The following is a description of a gene set: species: Mus musculus Mouse Gene Set: GOMF_KINASE_ACTIVITY Catalysis of the transfer of a phosphate group, usually from ATP, to a substrate molecule., and this is the list of marker genes: Nek6, Ccno, Nek3, Npr1, Fam20c, Plk4, Nrg1, Pdgfra, Fgfr2, Trp53rkb, Spred2, Gm7168, Igtp, Fgfr3, Map3k8, Grm5, Fermt2, Mast3, Gucy2f, Tkfc, Nme7, Hspa5, Phkg2, Pik3c2b, Irs3, Camkv, Cdk19, Hk2, Egf, Tyro3, Adk, Mark4, Etnk1, Fer, Ins1, Pmp22, Agap2, Ros1, Lrrk2, Ccl3, Ephb1, Mok, Sgms1, Itprip, Bcr, Ankle2, N4bp2, Prkar1a, Parp16, Prps1, Ccnj, Prpf4b, Cdk5r1, Pank1, Cab39, Nrbp1, Jak2, Spdya, Pfkfb3, Myo3b, Lamtor3, Mapk7, Pi4k2a, Dguok, Sephs1, P2rx7, Blk, Mapk8, Nek5, Tgfbr3l, Dclk1, Aatk, Pik3c3, Mylk3, Mknk2, Ttbk1, Pkdcc, Mast4, Rack1, Mapk11, Stk24 (NCBI Gene Id 69763), Rad50, Eef2k, Wnk2, Itsn1, Npr2, Cdkl2, Map3k20, Pim1, Ptk6, Cdk9, Rplp1, Prkdc, Sgk1, Gykl1, Mt3, Cks1brt, Mylk, Tgfa, Trib1, Pik3r4, Rplp1rt, Pask, Limk1, Mapkapk5, Gckr, Stk38l, Mapk6, Ltk, Slk, Hipk3, Stk-ps2, Irs1, Ulk2, Sh3glb1, Bmp7, Uck2 (uridine-cytidine kinase 2), Shpk, Acsl1, Aldh18a1, Ak6, Sbk3, Speg, Rps6kb2, Nek2, Rbks, Hmgb1, Rheb, Hsp90ab1, Nek9, Pkn1, Dapk2, Mvk, Cdc42bpg, Tssk1, Prkg2, Trib2, Epha1, Stk26, Bub1, Dnajc3 (NCBI Gene Id 19107, DnaJ heat shock protein family (Hsp40) member C3), Mylk2, Pik3ip1, Csf1r (NCBI Gene Id 12978), Htr2a, Pip4k2c, Brsk1, Ccnl2, Scyl3, Ryk, Gk5, Pomk, Fgfr4 (NCBI Gene Id 212063), Stk39, Map3k6, Mob3b, Apc, Gdf2, Ern1, Tec, Nek7, Prkrip1, Mak, Vegfa, Dbf4, Mtor, Prkar2a, Prkaca, Sgk2, Smok3b, Camk1g, Clk4, Sh3bp5l, Cdkn1c, Nim1k, Mlst8, Ednra, Pkia, Alkal2, Mob1a, Ckmt2, Mup5 (major urinary protein 5), Mark3, Dazap2, Mob1b, Cdk10, Ipmk, Fgr, Akap11, Itpka, Mylk4, Tom1l1, Prkcd, Rps6kl1, Akt1, Socs5, Cdk13 (cyclin dependent kinase 13), Cdk3, Smcr8, Pan3, Flt3, Prkab2, Ripk2, Hexim1, Cad, Epha6, Npm1, Mapk12, Ppef2, Mapk3, Dgkb (NCBI Gene Id 217480), Srpk3, Csnk2b, Map4k3, Twf1, Lmtk2, Sik2, Ccnb1, Ckb, Pik3r6, Ccni, Pink1, Rac2, Sbk2, Chek1, Mknk1, Iqgap1, Mapk10, Areg, Flt1, Mmd, Gm17949, Pfkfb1, Ptk7, Vrk1, Mup11, Pals1, 1810024B03Rik, Dclk3, Ranbp2, Gm7358, Nrp1, Prkch, Map4k2, Sgms2, Sh3bp5, Brsk2, Atg14, Nek8, Dgki, Wdr81, Eif2ak4, Musk, Adck1 (NCBI Gene Id 72113), Plk2, Nme6, Dgkd (diacylglycerol kinase, delta), Map3k7, Uhmk1, Spry4, Cav1, Glyctk, Tex14, Map2k4, Gucy2c, Chp1, Bmpr1b, Afap1l2, Sik1, Grk3, Srms, Nck1, Cdc37, Smg1, Braf, Epha10, Casp3, Uprt, Cdc42bpb, Dele1, Efemp1, Gprc5b, Tnik (NCBI Gene Id 99639), Ip6k3, Gcn1, Tcl1b4, Gk2, Adck5 (NCBI Gene Id 268822), Btc, Epgn, Prkag1, Lyn, Mark1, Alpk1, Alpk2, Pbk, Epha2, Prkra, Ephb2, Dmpk, Map3k21, Fn3krp (NCBI Gene Id 238024), Sostdc1, Ilk, Mapk13, Pank2, Cdk4, Gm14151, Fn3k, Abi1, Rock1, Kidins220, Ccnjl, Nrp2, Lrguk, Stk11, Mast2, Cask, Sphk1, Hyal2 (NCBI Gene Id 15587), Papss1, Pip5k1a, Insrr, Pgk1, Top1, Prkg1, Amhr2, Pik3r3, Tsacc, Prkaa2, Pip5k1b, Dgka, Mtcp1, Map3k10, Socs1, Tnni3k, Ddr1, Nek4, Pdk2, Pak1ip1, Src, Prkcz, Pfkp, Galk2, Alk, Taok1 (TAO kinase 1, NCBI Gene Id 67240), Pdpk1, Fggy, Taok2, Ripk4, Map4k1, Prkaa1, Mup3, Adpgk, Nmrk1, Tyk2, Dyrk3, Pkmyt1, Ttn, Stkld1, Lats1, Uckl1, Nolc1, Prkcb (NCBI Gene Id 319718), Dgkg, Ptk2, Ccl8, Map3k15, Cdkl4, Map3k13, Egfr, Nrg2, Ccna1, Itpk1, Rps6kb1, Clk1, Etaa1, Ccny, Lilrb4b, Map3k2, Rps6ka2, Prex1 (phosphatidylinositol-3,4,5-trisphosphate-dependent Rac exchange factor 1), Dusp22, Map4k4, Stk16, Taok3, Rgcc, Pim2, Dcakd, Wars1, Fgf13, Csnk1a1, Htatip2, Peak1, Map3k4, Kit, Cks2, Rictor, Map2k6, Stk19, Trio, Fgfrl1, Ttk, Gstp1, Prkcg, Ccnb1-ps, Ins2, Camk1d, Rubcn, Gskip, Pdxk, Gak, Gprc5d, Acvr2a, Fastk, Cdk11b, Mapk14, Tssk2, Ephb3, Syk, Hk1, Tgfbr3, Prag1, Dyrk1a, Hck, Rps6ka1, Pik3r2, Grk5, Lck, Pip4k2a, Nek1, Elp3, Sgk3 (NCBI Gene Id 72422), Ak2, Coq8b, Prkacb, Mup4, Itpkc, Brd2, Strada, Styk1, Ntrk3, Pfkm, Cdk15, Prps2, Ror2, Nrk (Nik related kinase), Grk6, Ak9, Ciita, Ptprc, Btk, Dgke (diacylglycerol kinase, epsilon), Mos, Ern2, Csnk2a2, Wee1, Cks1b, Tk2, Axl, Fam20b, Lilrb4a, Clp1, Nuak2, Pfkfb4, Araf, Camk2n1, Ulk3, Cdk5r2, Nadk2, Clk3, Ppip5k2, Mstn, Pikfyve, Eef1a1, Acvr2b, Zap70, Dgkk, Srpk2, Idnk, Hykk, Cib1, Grk2, Nagk, Gm7356, Nt5c2, Irs2, Spred1, Gne, Wee2, Ccl5, Hunk, Als2, Dgkq, Tnk2, Tab1, Ccnl1, Cert1, Eif2ak1, Tesk1, Atg13, Pkn3, Pip5k1c, Map2k2, Pak2, Mapkapk3, Macroh2a1 (NCBI Gene Id 26914), Camk2n2, Pi4kb, Parp6, Il6st, Nme3, Sbk1, Nme1, Met, Cep43, Angpt4, Pi4ka, Cdkn2c, Pdk3, Bmpr1a, Kalrn, Prkcq, Ntrk2, Pi4k2b, Mlkl, Dus2, Map3k1 (NCBI Gene Id 26401), Atr, Irgm1, Pip5kl1, Deptor, Camkk1, Csnk1g1 (casein kinase 1, gamma 1), Akt3, Rskr, Prkag3, Topbp1, Pak6, Aurkb, Ak5, Sav1, Pals2, Ckmt1, Stk32b, Plk5, Brd4, Ddx3x, Pik3c2g, Bccip, Daxx, Clk2, Hipk2, Limk2, Ccnb2, Epha7, Gm4922, Ccnd2, Ikbke, Prkag2, Pik3r1 (phosphoinositide-3-kinase regulatory subunit 1), Socs3, Rps6ka4, Map3k12, Ccnt1, Calm2, Baz1b, Smok2b, Acvr1b, Cdk16, Igf2, Cnppd1, Acvr1c, Ghrl, Lgals9, Irgm2, Irak3, Ccne1, Scyl1, Csk, Ephb4, Prkx, Cdk12, Igf1r, Dapk1, Nme2, Akt2, Ddr2, Nos2, Gsk3b, Acvr1, Prkd1, Pdk4, Camk2g, Sik3, Aurkc, Cdk2, Cdkl5, Map2k1, Sephs2, Etnk2, Hkdc1, Cdk1, Smok2a, Wnt11, Csnk1g3, Csnk1g2, Ippk, Epha4, Pgk2, Cdk8, Hjv, Mup2, Tcl1b2, Srpk1, Itpkb, Bckdk, Erbb2, Tssk4, Inca1, Parva, Pak3, Ereg, Tek, Guk1, Rps6ka3, Nmrk2, Cdc42bpa, Dgkz, Nme4, Chkb, Camk4, Ccna2, Cdkn2b, Map2k3, Hexim2, Trim24, Ppp1r9b, Tssk3, Irak4, Prkca (NCBI Gene Id 18750), Stradb, Cdkl1, Cdk14, Ulk1, Gprc5a, Stk32a, Prkci, Myo3a, Ccnf, Ikbkb, Trpm6, Alkal1, Hbegf, Eif2ak2, Rock2, Ccdc88a (coiled coil domain containing 88A), Jak1 (NCBI Gene Id 319959), Rps6ka5, Chuk, Prkd2, Mob2, Pip4k2b, Cerk, Tcl1b3, Matk, Lats2, Pklr, Pik3cg, Riok1, Tcl1, Ak8, Camk2d, Grk4, Dyrk2, Fyn, Gucy2e (guanylate cyclase 2e), Mbip, Ip6k2, Flt4 (FMS-like tyrosine kinase 4), Tlk1, Mertk, Acvrl1, Tie1, Gprc5c, D1Pas1, Aurka, Pde8a, Mob3c, Ercc6, Bmpr2, Rps6kc1, Gucy2d, Stk31, Rfk, Stk35, Map3k19, Ahsg (NCBI Gene Id 11625), Scyl2, Csnk1e, Bub1b, Mink1, Pkn2, Ttbk2, Pck1, Cd40lg, Ret, Pmvk, Fcsk, Ccnd3, Cdk6, Camkk2, Cdk20, Pank3, Cab39l, Cd24a, Nadk, Rps6ka6, Cpne3, Map3k11, Raf1, Prkar1b, Ccnb3, Tlk2, Csnk1d, Khk, Map3k5, Erbb4, Plk3, Nrbp2, Ripk1, Ulk4, Pnkp, Atad3a, Pxk, Trem2, Plk1, Ankrd42, Dyrk4, Xylb, Ibtk, Txk, Ywhab, Map4k5, Bmp2, Dcaf1, Stk25, Epo (NCBI Gene Id 13856), Ccnq, Itk, Elp1, Sphk2, Akt1s1, Calm1, Ip6k1, Trim28, Prkce, Cdkn1a, Stk10, Tssk6, 4921509C19Rik, Fgfr1, Tesc, Mst1, Calm3, Pik3r5, Htra2, Mmd2, Stk40, Smok3c, Dclk2, Coq8a, Atm, Ccng2, Ksr1 (kinase suppressor of ras 1), Melk, Ak4, Dusp19 (dual specificity phosphatase 19), Mup1, Vac14, Trib3, Kdr, Agk, Samd15, Pstk, Pfkl, Rhoh, Tcl1b5, Adipoq, Nek11 (NCBI Gene Id 208583), Pak1, Smok3a, Ccng1 (NCBI Gene Id 12450), Ankk1, Cdkn1b, Gck, Ajuba, Oxsr1, Cdk17, Dtymk, Cilk1 (NCBI Gene Id 70137), Cdk7, Hk3 (NCBI Gene Id 212032), Ccnh, Wnk1, Aak1, Pkig, Map2k7, Klf4, Pdk1, Tk1, Ankrd54, Map3k3, Jak3, Stap1, Tgfbr2, Pfkfb2, Mapk9, Camk1, Mast1, Ntrk1, Snrk, Mapk15, Alpk3, Cmpk1, Inka1, Riok3, Rptor, Phkg1, Pdgfrb, Pnck, Frk, Epha5, Cdkn2a, Vrk2, Ly6g6e (NCBI Gene Id 70274), Stk36, Mapk8ip2, Wnk4, Igf1, Camk2a, Pdik1l, Trpm7, Mnat1 (menage a trois 1), Pim3 (NCBI Gene Id 50885), Gsk3a, Pik3c2a, Grem1, Ccnk, Tpk1, Avp, Tcl1b1, Chek2, Tex24, Tbk1, Nbn, Stk32c, Fam20a (NCBI Gene Id 208659), Galk1, Ephb6, Coasy, Csnk2a1, Hipk4, Mapkapk2, Mark2, Cerkl, Nuak1, Ppp2r5a, Tesk2, Map2k5, Hspb1, Adck2 (NCBI Gene Id 57869), Ptk2b, Prex2, Bcl10, Prkar2b, Gk, Irak1, Camk2b, Bmp4, Bmp2k, Pkib, Eif2ak3, Tgfbr1, Wdr91, Ngf, Ppip5k1, Epha8, Dstyk, Mapk1, Grk1, Ak3, Smo, Qars1, Papss2, Ccnd1, Slc27a1, Rnasel, Gucy2g (NCBI Gene Id 73707), Stk33, Haspin, Dyrk1b, Mastl, Stk38, Parp8, Pik3cd, Cdkn2d, Blvra, Pskh1, Ccnc, Epha3, Cmpk2, Hipk1, Washc1, Pik3cb, Ak1, Pak5, Ccne2, Nek10 (NIMA (never in mitosis gene a)- related kinase 10), Irak2, Nckap1l, Ksr2, Riok2 (RIO kinase 2), Erbb3, Taf1, Lrrk1, Nol9, Fes, Ltf, Nlk, Cdk5, Mapk4, Pik3ca (phosphatidylinositol-4,5-bisphosphate 3-kinase catalytic subunit alpha), Prkd3, Malt1, Lmtk3, Dapk3 (NCBI Gene Id 13144), Tnk1, Dgkh, Tbck, Ak7, Spry2, Lrp6, Insr, Dolk, Pkm, Pak4, Tssk5, Inka2, Bmx, Abl1 (NCBI Gene Id 98922), Elp4, Ripk3, Chka, Ccnt2, Cdk18, Map3k14, Abl2, Stk3, Mob3a, Ckm, Cdkl3, Obscn, Prkab1 (NCBI Gene Id 76283), Map3k9, Mst1r, Cit, Pank4, Stk17b, Rassf2, Uck1, Kat2b, Wnk3, Cdc7, Tgfb1, Nme5, Ror1, Trp53rka, Yes1, Pgm2l1, Dck, Dab2ip, Vrk3, Stk4 (serine/threonine kinase 4)